The following is a description of a gene set: Cluster PAM2: genes up-regulated in hepatocellular carcinoma (HCC) vs normal liver tissue from mice deficient for TXNIP. Human Gene Set: SHETH_LIVER_CANCER_VS_TXNIP_LOSS_PAM2 species: Mus musculus from publication Sheth SS, Bodnar JS, Ghazalpour A, Thipphavong CK, Tsutsumi S, Tward AD, Demant P, Kodama T, Aburatani H, Lusis AJ (PMID 16607285) The molecular pathogenesis and the genetic aberrations that lead to the progression of hepatocellular carcinoma (HCC) are largely unknown. Here, we demonstrate that the thioredoxin interacting protein (Txnip) gene is a candidate tumor suppressor gene in vivo. We previously showed that the recombinant inbred congenic strain HcB-19 has a spontaneous mutation of the Txnip gene, and we now show that the strain has dramatically increased incidence of HCC, and that the HCC cosegregates with the Txnip mutation. Approximately 40% of the Txnip-deficient mice developed hepatic tumors with an increased prevalence in male mice. Visible tumors develop as early as 8 months of age. Histological analysis confirmed the morphology of HCC in the Txnip-deficient mice. Molecular markers of HCC, alpha-fetoprotein and p53, were increased in tumors of Txnip-deficient mice. The upregulation of p53 preceded tumor development; however, bromodeoxyuridine (BrdU) labeling of normal hepatic tissue of Txnip-deficient mice did not reveal increased cell proliferation. Finally, microarray analyses of tumor, non-tumor adjacent, and normal tissue of Txnip-deficient mice highlighted the genetic differences leading to the predisposition and onset of HCC. Our findings suggest that Txnip deficiency is sufficient to initiate HCC and suggest novel mechanisms in hepatocarcinogenesis., and this is the list of marker genes: PGM1, NOL12, SCN8A, EFNB2, WNK4, UNC119, PTTG1, CD93, PAWR, RRM2, CYP39A1, MCM2, TUBB2A, PSRC1, AKR1B1, DLG4, TGFBR2, STT3A, GOLM1, LYSMD2, LYVE1, PEG3, TAGLN2, VNN1, ROGDI, PRSS8, PLS1, ABCC5, PAQR4, MCAM, DDR1, BMP7, CKLF, DDIT3, MAL, ADGRG1, MVK, ANXA2, SLC1A4, TSPAN8, CD14, EIF2AK3, ACSL4, RHOC, BTG2, ABCB1, RAB3C, GRIA3, ATF3, BCL2L14, SLC39A4, SCD, AGFG1, PLSCR1, HSD3B2, CERK, WNT10A, TWF2, CLCF1, TANC1, MORC4, TUBA8, TAX1BP3, MIOX, BTG3, B4GALT6, PTPRE, ARHGAP12, FMNL3, MYO9B, UAP1L1, AJUBA, DAB1, RBP1, HEPH (NCBI Gene Id 9977), TLE6, DIP2B, ABHD5, MACIR, COMTD1, PTGR1, IL1RN, ARHGAP18, H1-2, CAV2, FGD1, TRIB3, SLC12A4, SPARC, NPDC1, UPP1, RUNX2, PFKFB3, CFAP184, RDH16, SIRPA, SKA2, CENPH, NAP1L1, SEL1L3, TNFSF13, MYO7B, LPL, DSG2 (desmoglein 2), DNAJC10, DUSP6, RAB34, TAGLN, DDX25, SMPDL3B, TMEM45B, EIF2AK4, COL4A4, DYNLL1, CCNB1 (cyclin B1), TOR4A, RPAP3 (RNA polymerase II associated protein 3), ELAPOR1, APP, QSER1, CTSG, GSDME, RTKN, COX5B, FSCN1, HID1, XYLT2, MEOX1, BEX1, CD40, POLD4, ABCD2, PNLIPRP2, NUF2, CYSTM1, KCNJ8, IER3, DMC1, LGALS1, TCEAL9, ERI2, MAP4K4, FKBP11, SLF1, INHBB, ZFP37, ZG16, H2AC8, BICDL1, TCEAL8, CCND1, PRRX1, COL4A1, GJC1, ACBD3, CD276 (CD276 molecule), PNPLA3, POFUT2, NENF, RASGRP2, TPM1, HMMR, ANXA9, MYADM, VAMP5, CHMP6, S100A11, TACC3